The following is a description of a gene set: species: Mus musculus Calcineurin activates NFAT Mouse Gene Set: REACTOME_CALCINEURIN_ACTIVATES_NFAT, and this is the list of marker genes: Ppp3ca, Nfatc3, Ppp3r1, Nfatc2, Fkbp1a, Calm3, Calm1, Ppp3cb, Calm2, Nfatc1